Given this list of marker genes RNF19B, PMAIP1, RNF19A, FOSL2, TREX1, ERAP2, GNB5, BAK1 (BCL2 antagonist/killer 1), PTPRA, GBP1, IL10RB, PENK, ITK, NOCT, S100A2, GK3, TIA1, FLT1, MOCOS, GNAT2, SCAF11, ZDHHC14, RARRES1, LYN, AK4, TANK, MACIR, TRIM25, MALT1, PLSCR1, SNAPC3, RIGI, PRSS3, CD248, BCAP29, ENPP1, BPGM, BRCC3, NRBF2, PSMB10, BST2, SOAT1, NPTX1, SKIC8, CXCL10, SLC12A8, SECTM1, STAT2, CYLD, BATF3, MX1, PSMB9, AFF4, RETREG2, MSRB1, SKI, TDRD7, SLC25A28 (solute carrier family 25 member 28), NKAPD1, LGALS8, MSX1, IFI35, KCTD20, IFIT1, MT1M, SLC30A4, RGL2, UBE2L6, DOCK10, IFIT3, IFIT2, P2RX5, TMEM140, RPE, STX17, HAUS2, GOT1, SLC31A2, HRH1 (NCBI Gene Id 3269), SMYD5, SLC15A3, HOXA1, ZNF609, PARP8, AMFR, BCL2L13, PSMB8, MBTPS2, OGFR, TRIM38, PTN, IFI6, PTPN12, TAP1, C1orf56, IRF1, ELF1, SP110, TAP2, HECA, CALR, ATXN7, UFM1, CSTF2T, RAB36, SOCS5, SLK, MBD5, ITGA6, ZFP36, PIK3CA, VAMP5, ZBED4, RAB27A, SETBP1, CCL20, ABHD17B, WARS1, MEIS3P1, ETS1, CCL7, RIPK2, BRD3, CHM, SOCS2, HERC4, ADPRM, IDO1, SP140L, IL6, USP18, CYP2A7, NMT2, CRADD, ATP10A, CHST3, MAFF, TUBA3C, LRFN4, NAMPT, PTGS1, ATF3, LONRF3, CSF1, SOCS1, SORT1, TSPAN5, SPRY4, P2RX4, NMI, DEPP1, APOL6, GSAP, IFITM1, FANCF, ICAM1, TEK, ZFP64, MED4, PARP12, EXOC2 (exocyst complex component 2), PCDH7, MX2, SWAP70, RACK1, PCDH9, GNA13, EIF2AK2, HSPB8, PRKAB2, TRIB2, SH2B3, RGS10, C3orf52, RB1, RXRA, DYRK3, THEMIS2, MAP3K7CL, RAB20, TRAFD1, IFI44L, HLA-J, TRIB1 (NCBI Gene Id 80272), ST3GAL1, IFI27, MOB1A, MID2, ZNF814, IL15RA, SP100, HERC6, DBF4, MOCS3, RINT1, KCNMA1, HK2, XAF1, PIGC, here is a description of the gene set: Pioglitazone treatment of CD4+FoxP3- T cells transduced with Pparg and Foxp3 up-regulated a set of genes whose products have been implicated in lipid metabolism pathways. To verify the specificity of this treatment, we performed microarray analysis on Foxp3+Pparg1-transduced CD4+FoxP3- T cells after treatment with other PPARg agonists such as Rosiglitazone (TZD) and GW1929 (non-TZD). studied in species Homo sapiens Human Gene Set: GSE37534_UNTREATED_VS_ROSIGLITAZONE_TREATED_CD4_TCELL_PPARG1_AND_FOXP3_TRASDUCED_DN from publication Cipolletta D, Feuerer M, Li A, Kamei N, Lee J, Shoelson SE, Benoist C, Mathis D (PMID 22722857) Genes down-regulated in CD4 T ceels over-expressing FOXP3 and PPARg1 isoform of PPARG: untreated versus rosiglitazone.